The following is a description of a gene set: studied in species Homo sapiens Human Gene Set: GOBP_VIRAL_GENOME_REPLICATION Any process involved directly in viral genome replication, including viral nucleotide metabolism., and this is the list of marker genes: SMARCB1 (SWI/SNF related, matrix associated, actin dependent regulator of chromatin, subfamily b, member 1), CNOT7, CCL8, EIF2AK4, CXCR6, CD28, BANF1, DDX56, ZC3H12A, OASL, GBP7, BCL2, LAMTOR5, N4BP1, DDX5, TRIM28, APOBEC3G (apolipoprotein B mRNA editing enzyme catalytic subunit 3G), ZNFX1, IFNB1, SHFL, IFI16, ZBED1, VCP, PCBP2, PPIA, CLEC4M, AICDA, ADAR, LTF, ISG15, ATG5, EIF2AK2, TMEM41B, NR5A2, PPIB, GAS6, VAPB, ZC3HAV1, ADARB1, IFITM1, YTHDC2, INPP5K, PKN2, GRK2, STOM, PCBP1, APOBEC3F, ISG20, NUCKS1, IFIT1 (interferon induced protein with tetratricopeptide repeats 1), RNASEL, APOBEC3D, SRPK1 (SRSF protein kinase 1), CD209, ILF3, APOBEC3A, SMC6 (NCBI Gene Id 79677), PPIH, LARP1, PLSCR1, OAS1, RSAD2, TRIM6, MX1, DDB1, VAPA, CCL5, IFI27, ATG16L1, BTBD17, PDE12, DEK, MIR221, TNIP1, TOP2B, PHB1, CXCL8, TMEM39A (NCBI Gene Id 55254), IFITM3, PPID, TOP2A, IFNL3, HMGA2, BST2, MAVS, PRKN, TARBP2, NFIA (NCBI Gene Id 4774), PPIE, APOBEC3H, ZFYVE1, SMC5, FAM111A, NOTCH1, CTBP1, TNF, PABPC1, DDX3X, STAU1, HACD3, CCL2, IFIT5, APOBEC3C, OAS3, FMR1, FKBP6, PIK3C3 (phosphatidylinositol 3-kinase catalytic subunit type 3), KPNA6, SRPK2, OAS2, FBXL2, MIR222, PROX1 (prospero homeobox 1), IFITM2, TRIM38 (NCBI Gene Id 10475), SLPI, TBC1D20, CTBP2, EEF1A1, IFIH1, CCNK, APOBEC3B, ATG16L2, RAD23A, SLC38A8